The following is a description of a gene set: Immune (humoral) and inflammatory response. Human Gene Set: MODULE_84 studied in species Homo sapiens, and this is the list of marker genes: HBA2, CD72, GMFG, FPR1, SELL, GNA15, PLEK, CASP1, DEFB104A, CCL5, CST7, KCTD17, MAFB, NKG7, DPYD, ACD, CD4, CD79A, MARCO, PRF1, PDGFRA, NINJ1, BIRC3, SAMSN1, PECAM1, IL4R, ORM2, TAP1, FCGR2A, ID2B, OLR1, CHIT1, CRIM1, CXCL9, TRIB2, CXCL12, CSF1R, UBE2L6, HSPA6, CD302, CYTH4, FADS1, ANKFY1, STMN1, CA4, ARHGAP15, JCHAIN, THRA, CREG1 (NCBI Gene Id 8804), BCL6, TNFAIP8L2, LGALS9, ICAM1 (intercellular adhesion molecule 1), NRGN, HLA-A, DKK4, PTPRE, DEFA3, VCAM1, TNFRSF25, VCAN, CAPG, CD163, F13A1, TGM2, TIMP2, IRF8, SLC7A8, SRRM2, LRCH4, IFNGR1, IL3RA, CD69, ISG15, LGMN, CYP1B1, CLEC2B, ITPR1, CLDN5, FN1, CD3D, LTC4S, IFI44L, KRT4, GPX3, ITM2A, RBM38, RAC2, IL6, AOAH (acyloxyacyl hydrolase), IFI30, C7, CCL19 (C-C motif chemokine ligand 19), APOC2, IFI35, ACSL1, PLAC8, ALOX5, LAIR1, RARRES2, IL10RA, TP63, CSF3R, PLA2G7, S100A4, CCR1, LCP1, ATP4A, PSD4, RUNX3, SLC40A1, PLAU, SPIB, CFD, LRIT1, MYL9, TNFSF12, IGHG3, MAN2B1, AQP1, CLEC3B, SLC38A10, TNFAIP8, SELENOP, MPO, ACP5, CYBA, NGFR, HLA-C, SECTM1 (NCBI Gene Id 6398), TYROBP, CCL3, CEACAM3, SEMA4A, FAM53B, HLA-DRB5, ISG20, SRPX, ODF1, STX11, IGFBP3, DDIT4, KRT14, COL6A1, MAL, CNTN6, GPSM3, SLC16A3, N4BP2L1, NHERF1, FGR (FGR proto-oncogene, Src family tyrosine kinase), DHRS3, NR0B2, CXCR4, CHST15, CD300A, CDH1, AEBP1, LMO3, PTPRCAP, COL6A3, S100A11, FGL2, C1QC (NCBI Gene Id 90369), GZMK, CD52 (CD52 molecule), LSP1, PPBP, KRT18, TGFBI, IGLJ3, A2M, APOC1, IGHM, ZYX, LORICRIN, CD5L, GBP2, ATOSB, FABP4, SELPLG, IGFBP4, DGKA, WNT10B, MRC1, SPSB1, TLR2, IGKC, IL2RB, CYP27A1, TNFSF10, CCL21, IGSF6, ANPEP, QPCT, SERPINE1, LIPA, BAIAP3, HTR4, NECTIN2, KIF21B, DUSP6, CCL2, LILRB3, HLA-DPA1, PSG7, HLA-DPB1 (NCBI Gene Id 3115), ST3GAL5, KRT5, DOCK2, UBXN1, LGALS3, RHOH, ST6GALNAC4, SRGN, SLCO2B1, PER1, NNAT, TNFAIP3, TSC22D3, FCN1, GNLY, RGS1, OLFML2B, CFP, ACTN1, PI3, MUC1, TACC2, CD27, CCL7, ITGAM, CXCL1, VWF, COMP, ARHGDIB, UBE2D1, GJB1, PIM2, APOE, IRF1, CD37, GLRX, EVI2A, CELF2, IGFBP2, MME, PPP4R2, AP1M1 (adaptor related protein complex 1 subunit mu 1), ABCA1, DNASE1L3, MYH11, CCDC9, LILRA2, MS4A4A, IL2RG, SLPI, TRIM22, ADIRF, IKBKG, GPR65, RAB31, CCNF, IRAG2, SYNE1, TGFBR2, CD53, PLBD1, KRT19, CTSC, KYNU, HCK, SPP1, IL1B, MX1, POMZP3, C1QB, PTPN7, COX7A1, RBP1, GRN, HLA-DRA, TLR1, MGLL, FCGRT, TNF, IFIT1, EDA, ADM (NCBI Gene Id 133), HCLS1, STAT1 (NCBI Gene Id 6772), SLC7A7, LMO4, CCL11, CSTA, GSTM1, TAGLN, IL1RN, ST6GAL1, NCF2, IER3, EXOSC2, S1PR4, KCNQ3, IL1RAP, ACR, MX2, CRYAB, RUBCNL, GFPT2, IL32, PTPRC, TDO2, SLC15A2, CD247, FOXG1, ITGB2, CD22, CEP135, PTP4A3 (NCBI Gene Id 11156), MB, ALPL, CD8A, GIMAP4 (GTPase, IMAP family member 4), SLC6A2, NUPR1, GPNMB, CES1, SNCG, CD74, RNASE1, ITGAL, HSPG2, FPR2, EVI2B, LYZ, IFI27, COL6A2, FGFR1, GCH1 (GTP cyclohydrolase 1), LYN, CDKN1A, LIF, CTSS, TRIM29, PDE4B, HLA-DQB1, ALOX5AP, RNASE6, B2M, MARF1, EMP3, BMP1, TNFAIP2, MSI1, PCOLCE, RGL1, MAT1A, ITGA6, ARHGEF6, OLAH, LMO2, TRDD3, CHI3L2 (NCBI Gene Id 9155), DBP, CCND2, CD209, LAMP3, S100A8 (S100 calcium binding protein A8), RABL6, S100A9, CX3CR1, CXCL16, SIT1, MFAP2, HK3, ZBTB20, CD14, PPL, C2, TSPAN4, SLC22A18AS, PLSCR1, IL27RA, APOD, JUNB, ENPP1 (ectonucleotide pyrophosphatase/phosphodiesterase 1), PLEKHO2, KRT15, LRRC32, TRPV2, IGFBP7, FCER1G, CD2 (NCBI Gene Id 914), SLA, TSPAN7, MST1L, ECE2, ITGB7, BASP1, ACTA2, VSIG4, IKZF1, NAMPT, LST1 (NCBI Gene Id 7940), COL4A1, KDM5D, CD8B, IFI44, SIX6, PLEKHO1, HLA-DRB1, COL1A2, NAPSA (napsin A aspartic peptidase), PNRC1 (NCBI Gene Id 10957), GZMA, LTB, C3AR1, GAS1, SDC1, KCNA5, LAP3, ADAM19, H2BC12, ADH1B, SMTN, GMEB1, ANXA1, DDX3Y, LTF, DEF6, APOC4, FOLR2, AMELX, TNFRSF13B (NCBI Gene Id 23495), IFI16, TNFRSF10D, AQP9, RAMP2, TBC1D2B, FCGR2B, LTBR, SLC7A11, PLIN2, CCL18, COPE, MDK, IL7R, NCF1C, RGS10, SEMA4D, S100P, FERMT3, ACKR1, NCF4, ADAMTSL4, GZMB, SERPING1, DHRS2, EPB41L3, CCL4, MAGI1, MS4A7, HLA-DMA (major histocompatibility complex, class II, DM alpha), CYSTM1 (cysteine rich transmembrane module containing 1), MNDA, STK17B, PLEC, DNM2, TNXB, LAMA3, VSIR, PLAAT4, PTGDS, TBX1, CD48, M6PR, ITPR3, DVL1, FST, PDE2A, C1S, HLA-DRB3, CORO1A (coronin 1A), CD6, CPVL, CCND1, ITGA10, MMP9, CADPS2, CLDN9, ATP2A3, KRT86, RAB3IL1, MTUS1, TNFRSF1B, CRABP1, STAT4, PFKFB3, KCND3, IL1R1, GBP1, SERPINA1, BCL2A1, TYMP, PARP12, SCN2B, STOM, ICAM3, HLA-DQA1, LCP2, TNFAIP6, PARP14, TFF3, LCK, AIF1, TCL1A, TCF7, PRELID3A, CAV1, NNMT, CYBB, CD86, LILRB2, LILRA4, LILRB1, SDS, RNASE2, UBD, ENTPD2, SASH3, SFTPC, LAPTM5, SLC25A39, CXCL8, SLAMF8, NRG2, FCGR3A, CCHCR1, ENG, DAB2, TBXAS1, CCL15, TPO, ARHGDIG, FKBP5